Given this list of marker genes AREG (NCBI Gene Id 727738), HDAC6, PRICKLE1, ACTN3, MACF1, GATA6, SYT4, COL27A1 (collagen type XXVII alpha 1 chain), MDK, GHRH, RAI1, RAD51B, NTRK3, CDK1, IL7, CCL11, DIP2B, DDR1, MEIS1, FZD9, IFRD1, NDUFS6, BMPR1B, SPAG9, NPY1R, FLRT1, CLIC4, EXT1, FSTL4, MFSD8, ANAPC2, SPTBN4, ACACB, NOG, NCAPG2, NEDD4L, PAK1, ALCAM (activated leukocyte cell adhesion molecule), MYOZ1, TBX2, STC1, TM4SF4, SLC12A5, NGF, GPX1, SYT1, WNT3A, ST8SIA2, C9orf72, CDKN1B, MAEL, CPQ, CLASP2, TOMM70, ZEB2, CD2AP, FES, PEX5, SCAPER, ZMIZ1 (zinc finger MIZ-type containing 1), CFLAR, WNT7A, G6PD, RUNX1, PPP3CA, SORBS2, SSNA1, TTC8, TEC, SOX9, PLAC8, UNC13A, KIAA0319, CCNB1, TMEM38B, POU4F3, SASH3, WNT7B, COL6A1, FGF7, HELT, MIR1-1, MIR199A1, RASAL1, SH3GL2, ZFY, PALB2, COL14A1, RYK, ABL1, DRD2 (NCBI Gene Id 91906), ESR1, ADRB2, TAF8, TGFB1, STAT3, TNC, MIR17HG, EPB41L5, POU3F2, ATM, IFT80, CER1, LHX2, ZNF830, GAREM2, TSC22D4, HDAC3, ULK1, SLC6A4, SYT17, FGF10, KMT2D, DSCAM, LIMK1, TMEM182, NRP1, RAB21, RIMS1, WWC2, GINS1, SLC1A2, SLC9A6, RXRB, PIK3CA, MMP13, SALL4, SHH, SPG21, SPP1 (secreted phosphoprotein 1), MAPK14, WT1, PDZD11, MAP1B, LATS1, WDR48, GPAM, WNT11, PLXNA4, CPNE5, DDR2, PRKG1, CHEK1, PRKAR1A, MEF2C, TGFB2, CHRND, COPS2 (COP9 signalosome subunit 2), POSTN, GALNT3, VPS13A, SMO, SOX2, SFRP2, NTN1, INSR, SPRY2, ITGA4, CHRNA1, MIR873 (NCBI Gene Id 100126316), EFNA5, PPP1R13L, CACNA2D2, MT3, FGF9, GMNC, RNF6, PLCB1, SMAD2, RTN4, TLL2, APOD, AMH, IST1, EIF2AK4, UBTFL1, TP73, ACVR2B, SMAD3, MIR199B, MIR24-1, KDM5B, PAK6, PLEC, TMEM108 (NCBI Gene Id 66000), BCL11A, EZR, COA5, SYT14P1, PPP3CB, ERCC2, NINJ1, WWTR1, SLC39A12, ATRX, KLK6 (NCBI Gene Id 5653), MSX2, TGFBR3, GRHL2, SMAD4, BBS2, FLVCR1, USP9X, EN1, KLF5, TARBP2, VIL1, ADARB1, POC1A, PTPRS, PAFAH1B1, GAS1, NIPBL, MUSK, RGS2, CAPN3, PTPN12, PELO, BMP4, SPAG6, MIR548C, SLIT3, EP300 (E1A binding protein p300), DMBX1, TNR, WNT10B, TBCE, YY1, SEMA3A, MIR23A, MIR590, FTO, CXCL12, TENM4 (NCBI Gene Id 26011), MATN1, RGMA, ERCC1, NPPA, MEGF8, RARG, SLC23A2, ZP3, DRAXIN, BCL9, DISC1, ETNK2, BMP10 (bone morphogenetic protein 10), NRG1, STAT5A, ZMPSTE24, LIN7C, FLRT3, ADRA1A, FOXP1, IQGAP1, CELA1, FOSL2, PLS1, FXN, SYT3 (NCBI Gene Id 84258), MIR208A, SIX1, EZH2, WWC1, NINJ2, GJE1, PTK7, GOLGA4, GNAT2, LAMB2, MAP3K13, SLC6A3, NRN1, VCL, DNM2, APOA5, MIR222, TFAP2C, PRKCZ, CRABP2, SMPD3, DNAAF3, CREB1, CHD7, FOXC2, SOS1, SOCS2, CCM2, EDNRA, MIR19B1, ACVR1C, MYOD1, GSK3B, HOPX, ITGB1, XIRP1, GJD4, GDI1, NRP2, VANGL2, AR, PPARA, CDH4 (cadherin 4), GPR21, ADAM15, APBA1 (NCBI Gene Id 320), PUM2, BCL2, GDF15, OTOA, POU4F2, SEMA6D, CCN3, EDN1, MKKS, CDH1, CDKL5, RBPJ, PIM1, TAL2, MUSTN1, ERCC6, COMT, MYMX, RTN4R, ADRB3, CLDN18, TRIM28 (NCBI Gene Id 96054), AKT1, ALKBH1 (NCBI Gene Id 8846), THBS3, SEMA4F, STIL, TWF2, COBL, L1CAM, GATA3, LHX1, APP, BASP1, ATRN, GNAT1, CHST11, ATP8A2, NOTCH1, RSPO2, DVL1, HESX1, LIN7A, NRCAM, TGFBR2, H3-3A, SLIT2, ZFYVE27, SIX4, GLI3, PAX7, LZTS2, MSTN, RTF1 (RTF1 homolog, Paf1/RNA polymerase II complex component), CTTN, MIR509-1, GAMT, LGMN, MYF6, DIPK2A, H3-3B, VGLL4, PLAG1, P2RX5, EDN3, PTCH1, RIMS2, SGPL1, RAPH1 (Ras association (RalGDS/AF-6) and pleckstrin homology domains 1), PPIB, OLFM1, MIR25, SMAD7, STK40, LGR6, JARID2, HSF1, DUSP6, CTNNB1, TSKU, ARHGAP4, LEPR, XRCC2, DAG1, CYP19A1, KRAS, CDK5, NKD1, MIR29B1, GLI1, TNS2, MYH10, HNF1B, FGF13, TNFAIP6, RBBP6, MTOR, EREG, FBLN5, BMPR2, PRPF19, ADPRHL1, NIN, PRKN, COLQ, G6PC1, CD81, SBDS, PSAPL1, GINS3, EHMT2, STRA6, RNF157, MAP2, GPAT4, TNN, RBP4, NACA, DCC, SOX10, HOXA5, AKAP6, STC2, SLIT1 (slit guidance ligand 1), CDKL3, ASCL3, BMPR1A, SALL1, LLGL2, EVC, CTR9, NLGN4X, SEMA3F, RMI1, GLI2, ADM, LRP4, CFL1 (cofilin 1), BBS4, NDRG4, YBX3, DIO3, SELENON, GHSR, LEP, GSK3A, SERP1, ARIH2, SLC25A25, RDH10, TAF10, IGF1, PTGFRN, HEY2, NPPC, SELENOM, ARX, MYCBP2, PYGO2, MED1, TMED2, GHR, WDR11, ECM1, KLF2 (KLF transcription factor 2), MAPK11, B4GALNT2, NBN, GATA4, PRLR, SPAAR, CD9, TBX20, PLXNA3, GRN, RGS4, CGA, GAP43, EDN2, POR, NDEL1, CTC1, BRCA2, CYFIP2, NLGN3, RASAL2, TBL1XR1, FN1, COMP, UBE3A, KAT2A, FGF8, CYFIP1, CPNE1, SPG11, RAG2, ADRB1, IGFBP1, SEMA4D, SEMA6C, KCNK2, MED12, FOXC1, TBX5 (NCBI Gene Id 6910), ANXA1, APBA2, KDF1, AURKA, DUSP10, DCLK1, ATF5, PSAP, KCNJ8, MAG (myelin associated glycoprotein), ZPR1, ITSN2, PLEKHA1, PPARD, BARHL2, WNT5A, FGFR3, SLC4A10, GAS2, PI16, CAV3, SIX3, PKDCC, GH1, AUTS2, MIR200B, SPART, DCAF13, STAT5B, EIF4H, MUL1, ODAD3, GPR149, LATS2, ZFP36L1 (ZFP36 ring finger protein like 1), BCL2L11, EYS, STK11, PRLH, CSF1, PLAA, FOXL2, VEGFA, RUFY3, NDN, AGRN, PTN, LIN7B, SEMA3G, INTS1, CPNE6, FGF2, ADCY10, TRIM46, SYT2, SOD1, PRMT2, SPRY1, FOXO3, OSTN, PARP2, ARID5B, ATG16L1, FKBP8, RARB, ASPM, GIGYF2, SRF, SHTN1, TGFBR1, HDGFL2, SFRP1, IER3IP1, STK4, NKX6-1, COX10, PTEN, FZD7, CPNE9, SPTBN2, WWC3, XPA, SLITRK1, TRPC5, ATN1, PPP2R3A, NOTCH2, BNC2, SMURF1, NPR2, EMX1, AAAS, TNFRSF12A, SMAD1, MEX3C, AKIRIN1, SEMA7A, IGF2, SUV39H1, WASF1, FGFR2, SIN3A, LARGE1, MYH6, HEG1, ZFPM2, WNT3 (NCBI Gene Id 7473), BIN3, SLITRK6, GDF5, ULK2, PROX1, MCUB, ADNP, FOXS1, STK3, S1PR1, HOXA11, CLSTN3, NRN1L, ERBB4, GPX4, TP53, GUCA2B (NCBI Gene Id 2981), FGF1, PDLIM5, NKX2-5, GINS4, SEMA5B, SOX15, MIR19A, GNAS, KPNA1, SCNN1B, SKI, APOE, MBD5, RARA, MIR204, TTL (tubulin tyrosine ligase), VPS13B, GHRL, BDNF, ARID2, MAPT, FSHR, KIF26B, PLG, GHRHR, SAV1, PHLDA2, WDTC1, CDKN1C, HLX, PLXNA1, ATF2, EPHA7, BRINP3, MIR195, VPS54 (NCBI Gene Id 51542), DLL1, LPAR3, MTM1, GPD2, YAP1, HMGA2, MESP1, FKRP, COL3A1, RC3H2, S100B, MYMK, CDKN1A, CACNG7, GDF9, ISLR2, FGF20, BRINP2, RND2, IMPACT, LLPH, CTDP1, IHH, FGFR1, PTX3, PTPN11, TRPV2, HTRA2, SEMA5A, MFSD2A, NR5A2, HOXD13, EPPK1, AGR2, WNT2, BLOC1S6, AFG3L2, GAREM1, here is a description of the gene set: The increase in size or mass of an entire organism, a part of an organism or a cell, where the increase in size or mass has the specific outcome of the progression of the organism over time from one condition to another. species: Homo sapiens Human Gene Set: GOBP_DEVELOPMENTAL_GROWTH